Given this list of marker genes Cd22, Kcnc1, Atp2b1, Reg1, Amigo1, Gria1, Kcna2, Kcnb1, Cx3cr1, P2ry12, Kcnc3, Thy1, Tacr3, Kcnc2, Dab2ip, Adrb2, Rgs8, Il6ra, Atp2b2, Mrgpra3, Slc6a2, Il6st, Kcne3, Kcnj6, Unc5a, Aqp1, Kcnd2, Cadm2, Nradd, Gabra6, Atp1b2, Insr, Slc4a8, Piezo2, Adcy8, Kcnc4, Kcnb2, Gabra5, Ngfr, Hpca, Flrt1, here is a description of the gene set: species: Mus musculus Mouse Gene Set: GOCC_CELL_BODY_MEMBRANE The plasma membrane of a cell that bears surface projections such as axons, dendrites, cilia, or flagella, excluding the plasma membrane on cell projections.